Given this list of marker genes KCNMA1, KCNN4 (NCBI Gene Id 3783), KCNN3, KCNMB2, KCNMB4 (NCBI Gene Id 27345), KCNN2, KCNMB3, KCNMB1, KCNN1, here is a description of the gene set: Ca2+ activated potassium channels are expressed in neuronal and non-neuronal tissue such as smooth muscle, epithelial cell and sensory cells. Ca2+ activated potassium channels are activated when the Ca2+ ion concentration increased, The efflux of K+ via these channels leads to repolarization/hyperpolarization of the membrane potential which limits the Ca2+ influx though voltage activated Ca2+ channels (VGCC) thereby regulating the influx of Ca2+ flow via VGCC. part of: Potassium Channels studied in species Homo sapiens Reactome Pathway: Ca2+ activated K+ channels